Given this list of marker genes MOCS3, ATG7, UBA1, UBA2, NAE1, UBA3, UBA6, UBA5, SAE1, UBA7, here is a description of the gene set: Human Gene Set: GOMF_UBIQUITIN_LIKE_MODIFIER_ACTIVATING_ENZYME_ACTIVITY studied in species Homo sapiens Catalysis of the activation of small proteins, such as ubiquitin or ubiquitin-like proteins, through the formation of an ATP-dependent high-energy thiolester bond.